Given this list of marker genes DNAJB14, CDK13, INPP5D, PIK3R1, ZBTB14, FBXL14, DDAH2, GSTM4, KLF4, LAT2, CHD1, PIBF1, BTBD7, DPY19L4, OAZ2, PGS1, TRAPPC11, CORO1A, CEP68 (centrosomal protein 68), RPS17P5, TNFSF13, DEK, CAPG, CD79B, ARHGAP24, PSME3IP1, S100A10, AVL9, FRAT1, SLC25A36, AUTS2, TLK2, MAP1LC3B, BAP1, APP, FIP1L1 (factor interacting with PAPOLA and CPSF1), POLR3C, GGPS1, ZNF529, USP6NL, SLC25A24, ZMAT3, TIPRL, WDR47, SPG11, NCOA1, ZNF157, PTK2, CSNK1G2, PHF20, ALOX5AP, SYNGR3, ZNF134, NFKB1, ANXA1, TRIM33, TRIM38, RHOH, GALT, PLEKHF2, ADAMDEC1, SH3BGRL3, PTBP2, ATP8A1, NFRKB, DENND2D (NCBI Gene Id 79961), MAML1, JADE1, IQSEC1, RHOG, JAM3, RUBCNL, NPLOC4, RASSF1, BTK, ZSCAN18, CYBB, TWF1, SMARCB1, SLC7A7, MOB4, TARBP1, MYD88, SNX10, TCEAL1, MEGF9, PLEKHO1, KDM3A, RPS6KA3, HCG4B, CRYBG1 (crystallin beta-gamma domain containing 1), METTL22, SEPTIN9, SNAPC1, CD22, CD74, TNFRSF10B, DUSP6, JADE3, PPP1CB, TWNK, SGMS1, AP1S2, CRK, OSGEP, SIAH1, MAPK1, NECAP2, AP3M2, MAN2B2, ALOX5, NUDT3, TMEM222, EXT2, CLK2, LBH, TP53BP2, ZFYVE26, SMARCAL1, PISD, ATP2B1, TCF20 (NCBI Gene Id 6942), YTHDC2, RAPGEF6, NAA40, CD19, SOCS1, ARID4B, CCNT2, PARP12 (poly(ADP-ribose) polymerase family member 12), MYC, RNF220, HHEX, LSM14A, TRAF3IP2, ATP6V0E2 (NCBI Gene Id 155066), MED14, DGKA, MCCC2, REPIN1, NDRG3, CAPRIN2, RPL31, RSBN1, TGFBR2, ZFYVE16, MCM9, TRAF4, PRPF3 (NCBI Gene Id 9129), VPS13D, CTNNBL1, TMUB2, METTL8, OSER1, NKRF, PMS2P2, RIPK2, ATAD2B, IL15, DDX60, PCNX1, SOS2, PPFIA1, RUNX3, EIF2B5, PRKX, MTR, CBLB, BTN2A1, SP100 (NCBI Gene Id 6672), PDZD8, ALDH5A1, ZSCAN32, DET1, LPGAT1, ZMYND8, MORC3, TRMT61B, BPTF, GIT2, RNFT1, LCK, USE1, GOLGA8B, BACE2, SCPEP1, HLA-DRB6, DCLRE1C, INPP5B, TRIM13, SNX29P2, PTK2B, DPH5, ZNF266, USP39, RYK, PARP8, PEX26, AKAP10, PTPRK, here is a description of the gene set: Enhanced secondary Ab responses are a vital component of adaptive immunity, yet little is understood about the intrinsic and extrinsic regulators of naive and memory B cells that results in differences in their responses to Ag. Microarray analysis, together with surface and intracellular phenotyping, revealed that memory B cells have increased expression of members of the TNF receptor, SLAM, B7 and Bcl2 families, as well as the TLR-related molecule CD180 (RP105). Accordingly, memory B cells exhibited enhanced survival, proliferation and Ig secretion, as well as entered division more rapidly than naïve B cells in response to both T-dependent and T-independent stimuli. Furthermore, both IgM and isotype switched memory B cells, but not naïve B cells, co-stimulated CD4+ T cells in vitro through a mechanism dependent on their constitutive expression of CD80 and CD86. This study demonstrates that upregulation of genes involved in activation, co-stimulation and survival provides memory B cells with a unique ability to produce enhanced immune responses and contributes to the maintenance of the memory B cell pool. Genes up-regulated in comparison of Ig isotype switched memory B cells versus plasma cells. studied in species Homo sapiens Human Gene Set: GSE13411_SWITCHED_MEMORY_BCELL_VS_PLASMA_CELL_UP from publication Good KL, Avery DT, Tangye SG (PMID 19124732)